The following is a description of a gene set: studied in species Mus musculus Mouse Gene Set: GOBP_POSITIVE_REGULATION_OF_LIPID_METABOLIC_PROCESS Any process that activates or increases the frequency, rate or extent of the chemical reactions and pathways involving lipids., and this is the list of marker genes: Apoa2, Zbtb20, Bmp6, Adora2b, Irs1, Ces1c, Gnai1, Gdf15, Cga (glycoprotein hormones, alpha subunit), Mlxipl, Mup1, Mbtps2, Apoa5, Qki, Mup11, Rgn (NCBI Gene Id 19733), Cyp7a1, Daglb, Igf2, Slc27a1, Mapk1, Il1a, Zfp750, Cnep1r1, Hsd17b13, Rdh10, Nr5a2, Angptl4, Irs2, Mlx, Sirt4, Ces1a, Rdh19, Nr1h3, Adipoq, Kat5, Fgf21, Clstn3, Ces1h, Abhd6, Mup5, Pcx, Avpr1a, Scarb1, Mup3, Mfsd2a, Il1b, Anxa1, Scap, Fdps, Agt, Apoc3 (apolipoprotein C-III), Rdh1, Disp3, Kat2b, C1qtnf2 (C1q and tumor necrosis factor related protein 2), Obp2a, Gpld1, Fgf1, Apoa1, Ces1b, Rack1, Ccdc3, Apoc2l, Spata18, Mtor (NCBI Gene Id 80612, mechanistic target of rapamycin kinase), Rab38, Creb1, Abcd2, Prkaca, Mlycd, Rdh16f2, Acsl3, Akt2, Mup2, Htr2c, Npy1r, Mapk9, Fabp3, Htr2b, Apoh (apolipoprotein H), Dbi, Twist1, Elovl5, Gh, Ccn1, Adgrf5, Dab2, Sorbs1, Ptgs2, Htr2a, Sct, Pla2g6, Por, Pla2g4a, Ppara, Ces1g, Mup4, Igf1, Smpd3, Sirt3, Crebl2, Rdh9, Prkcd, Ogt, Ppard, Fshb, Nr1h2, Plin5, Erbb4, Gpam, Nucb2, Slc45a3, Ppargc1a, Chp1, Cyp17a1, Eef1a2, Ces1e, Rdh16, Srebf2, Cpt1a, Nr1h4, Fabp1, Mtln, Star, Nsmaf, Enpp7 (ectonucleotide pyrophosphatase/phosphodiesterase 7), Dgat1, Dgat2, Ifng, Wnt4, Ins2, Ctdnep1, Capn2, Stard4, Sphk2, Cd74, Mlst8, Pck1, Sec14l2, Acsl5 (acyl-CoA synthetase long-chain family member 5), Abcd1, Apoc2, Aadac, Klhl25, Abhd5, Tcf7l2 (transcription factor 7 like 2, T cell specific, HMG box), Akt1, Igf1r, Nr1d1, Avp, Tnf, Abcg4, Ldlr, Rptor, Ghsr, F2, Tnfrsf1a (tumor necrosis factor receptor superfamily, member 1a), Angptl3, Pla2g3, Abcg1, Paqr3 (progestin and adipoQ receptor family member III), Apoe, Hnf4a, Sirt2, Pparg, Adora1, Sctr (secretin receptor), Lpgat1, Eed, Srebf1, Pnpla2, Scp2, Prkce, Apoa4, Ces1f, Ces1d, Mid1ip1